Given this list of marker genes Ctla4, Ppp2r5d, Ppp2r5b, Cd80, Ppp2r5a, Lck, Fyn, Yes1, Ppp2r1b, here is a description of the gene set: studied in species Mus musculus electronically inferred by orthology from the curated human pathway Reactome Pathway: Co-inhibition by CTLA4 This event has been computationally inferred from an event that has been demonstrated in another species.<p>The inference is based on the homology mapping from PANTHER. Briefly, reactions for which all involved PhysicalEntities (in input, output and catalyst) have a mapped orthologue/paralogue (for complexes at least 75% of components must have a mapping) are inferred to the other species. part of: Regulation of T cell activation by CD28 family